The following is a description of a gene set: Human Gene Set: HP_CRANIAL_HYPEROSTOSIS species: Homo sapiens Cranial hyperostosis Excessive growth of the bones of cranium, i.e., of the skull., and this is the list of marker genes: AKT1 (NCBI Gene Id 207), TNFSF11, GNAS, RPS6KA3, LRP5, THOC2, PIK3CA, COL1A1, KRAS, XPC, ERCC5, FLNA, OSTM1, ERCC4, TCIRG1, SOST, HNRNPA1, VCP, SLC39A14, PTDSS1, ALMS1, TBXAS1, ERCC2, HNRNPA2B1, SP7 (NCBI Gene Id 121340), GJA1, FGFR1, COX4I2, ERCC3, SLC29A3, TNFRSF11B, ANKH, LRP4, TNFRSF11A (NCBI Gene Id 8792), NOTCH3, DDB2, AMER1, CA2, XPA, MAN2B1, SMAD4, PRKAR1A, IDUA